The following is a description of a gene set: from publication Chen Y, Wang X (PMID 31504780) studied in species Homo sapiens Genes predicted to be targets of miRBase v22 microRNA hsa-miR-6804-3p in miRDB v6.0 with MirTarget v4 prediction scores > 80 (high confidence targets). Human Gene Set: MIR6804_3P, and this is the list of marker genes: LRFN4, EDEM1, PCSK5, NR6A1 (NCBI Gene Id 2649), ATL1, BCORL1, APBA1, YWHAG, MKRN2, DRD1, PLS3, PRKCE, MICAL2, SEPTIN3, IGSF3, WAPL, TXLNA, MAPK14, REV3L, RNF128, CACNA2D2, CNKSR2, PLPPR4, SOCS2, FNDC3B, PPP2R2C, ADCY5, SORCS1 (NCBI Gene Id 114815), NCOA1, GRIK4, MATR3, SAMD12, DNMT3A, SPAG11B, CHL1, CCDC121, CHST6, ADNP2, ZNF704, EPHA8, EDEM3, PPP4R1, TSHZ3, SOX12, YWHAZ, PTPN4, C9orf72, BRINP1, GPR173, MKRN1, NAALADL2, ERO1B, MARS2, SEPTIN9, KLHL18, SDE2, SLC36A1, KBTBD2 (kelch repeat and BTB domain containing 2), PSMF1, FERRY3, RRAS2, CCDC3, PPP3CC (NCBI Gene Id 5533), CNTN1, CIPC, PHOX2B, CAMK4, PUS7, NTNG1, SNTB2, DAAM1 (NCBI Gene Id 23002), NBEA, MOB1B, PDE8A, DNAH17, MBD2, LDHAL6A, CHST5, CRLS1, ACBD3, ETS1, KCNK10, SNAI2, IPO8, NNAT, MXI1, SLC25A36, ATXN1L, PHACTR3, MAP4K4, ELFN2, CCP110, TENM2, SLC25A26, PTPN12, LBP